The following is a description of a gene set: Enables the transfer of zinc from one side of a membrane to the other according to the reaction: H+(out) + Zn2+(in) = H+(in) + Zn2+(out). species: Homo sapiens Human Gene Set: GOMF_ZINC_PROTON_ANTIPORTER_ACTIVITY, and this is the list of marker genes: SLC30A6, SLC30A2, SLC30A8, SLC30A1, SLC30A5